Given this list of marker genes GNB2, SCAF4, MAP3K7, ZIC3, PPP1CB, FOXF1, PPP2R1A, NKX2-5, CREBBP, EP300, BCOR, GJA1, PUF60, CIROP, here is a description of the gene set: Human Gene Set: HP_HYPOPLASTIC_AORTIC_ARCH Underdevelopment of the arch of aorta. species: Homo sapiens Hypoplastic aortic arch